The following is a description of a gene set: Primitive reflex species: Homo sapiens Human Gene Set: HP_PRIMITIVE_REFLEX The primitive reflexes are a group of behavioral motor responses which are found in normal early development, are subsequently inhibited, but may be released from inhibition by cerebral, usually frontal, damage. They are thus part of a broader group of reflexes which reflect release phenomena, such as exaggerated stretch reflexes and extensor plantars. They do however involve more complex motor responses than such simple stretch reflexes, and are often a normal feature in the neonate or infant., and this is the list of marker genes: GLRB, RAB18, ST3GAL3, MME, TREM2, DCTN1, TUBB3, DNMT1, HADHB, SPG21, AARS1, CTSF, PSEN1, TYROBP, GM2A, JPH3, NGLY1, DNAJC6, PIGA, PIEZO2, ALDH18A1, ATP13A2, HADHA, NDUFS8, MAPT, DPM2 (NCBI Gene Id 8818), ZIC2